Given this list of marker genes Cnga4, Cnga1, Aqp1, Cngb1, Cnga3, Cngb3, Cnga2, here is a description of the gene set: species: Mus musculus Enables the transmembrane transfer of a cation by a channel that opens when intracellular cGMP has been bound by the channel complex or one of its constituent parts. Mouse Gene Set: GOMF_INTRACELLULARLY_CGMP_ACTIVATED_CATION_CHANNEL_ACTIVITY